The following is a description of a gene set: Mouse Gene Set: GOBP_RECOGNITION_OF_APOPTOTIC_CELL The process in which a cell interprets signals (in the form of specific proteins and lipids) on the surface of a dying cell which it will engulf and remove by phagocytosis. studied in species Mus musculus, and this is the list of marker genes: Scarb1 (NCBI Gene Id 52288), Jmjd6, Pear1, Megf10, Fcnb